Given this list of marker genes Irx3, Tbx5, Dsg2, Tbx3, Nkx2-5, Id2, here is a description of the gene set: Mouse Gene Set: GOBP_HIS_PURKINJE_SYSTEM_DEVELOPMENT The process whose specific outcome is the progression of the His-Purkinje system over time, from its formation to the mature structure. The His-Purkinje system receives signals from the AV node and is composed of the fibers that regulate cardiac muscle contraction in the ventricles. species: Mus musculus